Given this list of marker genes Pnp, Psma3 (proteasome subunit alpha 3), Mt1, Steap4, Ccl12, Fcgr1, Fcgr3, Isg15, Ccl6, Ifi204, Clec4n, Ccl7, Tmem268, Ptpn1, Saa3, Dok2, Wfdc17, Osgin1, Hmox1, Fcgr2b, Cxcl9, Eif4a1, Msrb1, Scimp, Ccl9, Ifitm2, here is a description of the gene set: Mouse Gene Set: CUI_MACROPHAGE_CARDIOTROPHIN_1_RESPONSE_UP from publication Cui A, Huang T, Li S, Ma A, Pérez JL, Sander C, Keskin DB, Wu CJ, Fraenkel E, Hacohen N (PMID 38057668) Cytokines mediate cell-cell communication in the immune system and represent important therapeutic targets. A myriad of studies have highlighted their central role in immune function, yet we lack a global view of the cellular responses of each immune cell type to each cytokine. To address this gap, the authors created the Immune Dictionary, a compendium of single-cell transcriptomic profiles of more than 17 immune cell types in response to each of 86 cytokines (>1,400 cytokine-cell type combinations) in mouse lymph nodes in vivo. A cytokine-centric view of the dictionary revealed that most cytokines induce highly cell-type-specific responses. For example, the inflammatory cytokine interleukin-1β induces distinct gene programmes in almost every cell type. A cell-type-centric view of the dictionary identified more than 66 cytokine-driven cellular polarization states across immune cell types, including previously uncharacterized states such as an interleukin-18-induced polyfunctional natural killer cell state. Genes positively differentially expressed in cell type: Macrophage upon treatment with cytokine: CT-1 in mouse lymph nodes in vivo. species: Mus musculus